The following is a description of a gene set: species: Homo sapiens Ca-dependent events Human Gene Set: REACTOME_CA_DEPENDENT_EVENTS, and this is the list of marker genes: CAMK4, ADCY2, PLA2G4A, GRK2, PRKAR1B, ADCY4, PDE1A, CAMKK2, PDE1B, CALM1, MAPK1, NBEA, PDE1C, PRKAR2A, ADCY3, CREB1, PRKX (NCBI Gene Id 5613), PRKACG, ADCY1, PRKCA, ADCY7, CAMKK1, ADCY9, CAMK2B, PRKAR1A, ADCY5, ADCY8, KPNA2 (karyopherin subunit alpha 2), ADCY6, PRKCD, PRKACA, PRKACB, PRKCG, PRKAR2B, CAMK2D, CAMK2G, CAMK2A